The following is a description of a gene set: from publication Chen Y, Wang X (PMID 31504780) Genes predicted to be targets of miRBase v22 microRNA hsa-miR-6505-3p in miRDB v6.0 with MirTarget v4 prediction scores > 80 (high confidence targets). species: Homo sapiens Human Gene Set: MIR6505_3P, and this is the list of marker genes: CD58, CXCL11, CBFA2T2, RFXAP, DNALI1 (dynein axonemal light intermediate chain 1), SLC1A3, TOR1AIP1, ZFP1, PDLIM5, PAK4, FRG2C, AGR3, NFAT5, LRP11, PTER, CCDC3, P2RX2, TGFB2, KRAS, ISL1, ARG2, YTHDF1, TMEM245, ALDOC, POU2AF1, CALD1, NIT1 (NCBI Gene Id 4817), RNF169, CEP15, BAALC, MYOCD, ST8SIA3, KRBOX4, E2F3, PAGE4 (NCBI Gene Id 9506), CEMIP, CHD6, RHOA, NSL1, MTHFD1, GHITM, OTOF, RBM27, SORBS1, BCL9L, SGTB, WAPL, SLC44A5, VRK2, STXBP1, ALG6, SRP68, NUAK1, ARL5B, HACE1, IL22RA2, ATF2, RAP1A, MYO1B, PRKD3, DMRT1, MAT2A, ARHGEF33, HSPD1, KCMF1 (NCBI Gene Id 57734), RTN3, ZNF25, PDGFRL, C4orf33, DGKH, PPFIA1, MAIP1, EDNRB, UBE2J1, DCUN1D2, ITGB1BP1, ONECUT2, ITPR1, ITM2A, NT5DC1, GAGE12D, HTR5A, ODF1, IL2RA (NCBI Gene Id 3559), TLCD2, SKIL, TRIB2 (NCBI Gene Id 28951), CEP350, TNKS, ENOSF1, SRPK2, LRRC40, PRKX, MFSD9, LYPD1, FRG2, S1PR3